Given this list of marker genes Pfkfb1 (NCBI Gene Id 18639), here is a description of the gene set: electronically inferred by orthology from the curated human pathway part of: Glycolysis This event has been computationally inferred from an event that has been demonstrated in another species.<p>The inference is based on the homology mapping from PANTHER. Briefly, reactions for which all involved PhysicalEntities (in input, output and catalyst) have a mapped orthologue/paralogue (for complexes at least 75% of components must have a mapping) are inferred to the other species. studied in species Mus musculus Reactome Pathway: Regulation of glycolysis by fructose 2,6-bisphosphate metabolism